The following is a description of a gene set: Mouse Gene Set: GOCC_CUL4B_RING_E3_UBIQUITIN_LIGASE_COMPLEX species: Mus musculus A ubiquitin ligase complex in which a cullin from the Cul4B subfamily and a RING domain protein form the catalytic core; substrate specificity is conferred by unknown subunits., and this is the list of marker genes: Ddb1, Wdr77, Dtl, Ddb2, Rbx1, Cul4b, Rbx1-ps